The following is a description of a gene set: Any process that activates or increases the frequency, rate, or extent of smooth muscle cell apoptotic process. Human Gene Set: GOBP_POSITIVE_REGULATION_OF_SMOOTH_MUSCLE_CELL_APOPTOTIC_PROCESS studied in species Homo sapiens, and this is the list of marker genes: RBM10, SOD2, MIR1-1, MIR140, PPARG, MIR28, IL12B, ADCY10, BAG1, FOXO1, ATF4, CDKN2A, IFNG, MIR24-1, PDCD4, STUB1, MFN2, E2F3, IL12A